The following is a description of a gene set: studied in species Mus musculus from publication Welch JJ, Watts JA, Vakoc CR, Yao Y, Wang H, Hardison RC, Blobel GA, Chodosh LA, Weiss MJ (PMID 15297311) Transcription factor GATA-1 is required for erythropoiesis, yet its full actions are unknown. We performed transcriptome analysis of G1E-ER4 cells, a GATA-1-null erythroblast line that undergoes synchronous erythroid maturation when GATA-1 activity is restored. We interrogated more than 9000 transcripts at 6 time points representing the transition from late burst forming unit-erythroid (BFU-E) to basophilic erythroblast stages. Our findings illuminate several new aspects of GATA-1 function. First, the large number of genes responding quickly to restoration of GATA-1 extends the repertoire of its potential targets. Second, many transcripts were rapidly down-regulated, highlighting the importance of GATA-1 in gene repression. Third, up-regulation of some known GATA-1 targets was delayed, suggesting that auxiliary factors are required. For example, induction of the direct GATA-1 target gene beta major globin was late and, surprisingly, required new protein synthesis. In contrast, the gene encoding Fog1, which cooperates with GATA-1 in beta globin transcription, was rapidly induced independently of protein synthesis. Guided by bioinformatic analysis, we demonstrated that selected regions of the Fog1 gene exhibit enhancer activity and in vivo occupancy by GATA-1. These findings define a regulatory loop for beta globin expression and, more generally, demonstrate how transcriptome analysis can be used to generate testable hypotheses regarding transcriptional networks. Genes up-regulated after GATA1 activation in G1E-ER4 cells (erythroid precursors engineered to express GATA1 upon addition of estradiol). Mouse Gene Set: WELCH_GATA1_TARGETS, and this is the list of marker genes: Uros, Nfe2, Alad, Hba-a1, Mafk, Slc4a1, Dmtn, Gstt2, Stom, Tfrc, Mafg, Abcb10, Urod, Hba-x (hemoglobin X, alpha-like embryonic chain in Hba complex), Bach1, Gypa, Zfpm1, Hbb-y, Ppox, Klf1, Ftl1, Ank1, Hmbs (NCBI Gene Id 97580), Alas2 (aminolevulinic acid synthase 2, erythroid)